Given this list of marker genes CLIP3, NFKBIA, RIPK1, ARHGEF37, USP4, ARHGEF18, ARHGEF3, MAG, FAS, ARHGEF33, APH1A, RNF31, ECT2, TIAM1, SMPD3, YWHAE, CYLD, RASGRF2, RELA, OTUD1, RPS27A, RBCK1, PSEN2, RHOA, MADD (MAP kinase activating death domain), BIRC2, SPATA2, TNFSF10, IKBKE, ARHGEF26, UBE2D2, HDAC2, ARHGEF38, CHUK, TNFRSF10B, ARHGEF10L, ARHGEF11, ARHGEF35, SPPL2B, TBK1, MCF2L, PSEN1, MAPKAPK2, ARHGEF17, USP21, IKBKG, ARHGEF6, SQSTM1, TNF, SOS1, TNFRSF1A, NFKB1, VAV1, STUB1, MAGED1, TNFRSF10D, OPG199, TAB1 (NCBI Gene Id 10454), UBE2L3, ARHGDIA (Rho GDP dissociation inhibitor alpha), UBC, TIAM2, SOS2, FASLG, CASP3, AATF, SPPL2A, ITGB3BP, KALRN, CASP2, UBB, OBSCN, NCSTN, TRAF1, PLEKHG5, NGFR, RIPK2, OTULIN, RAC1, ARHGEF19, MYD88, TRADD, FGD1, ARHGEF39, OMG, ARHGEF7, PREX1, MCF2, FGD4, IRAK1, CASP10, UBA52, IKBKB, ARHGEF4, PSENEN, CFLAR, AKAP13, UBE2D1, MAP3K7, ADAM17, ARHGEF1, CASP8, FADD, NSMAF, TAB3, ARHGEF15, BCL2L11, OPTN, MIB2, TRAF6, SMPD2, PLEKHG2, ITSN1, NET1, UL36, BIRC3, ARHGEF12, TAB2, RTN4R, NGF, GNA13 (NCBI Gene Id 147219), SHARPIN, VAV2, TNFRSF10A, TRIO, APH1B, ARHGEF9, XIAP, VAV3, RACK1, FGD2, BEX3, ULK1, ARHGEF40, OTUD7B, BAD, BAG4 (BAG cochaperone 4), TRAF2, ARHGEF16, TAX1BP1 (Tax1 binding protein 1), HDAC3, PRDM4, RTN4, ABR, USP2, MAPK8, HDAC1, LINGO1, ARHGEF5, TNFAIP3, PRKCI, SORCS3, ARHGEF10, UBE2D3, FGD3, ARHGEF2 (NCBI Gene Id 9181), NGEF, here is a description of the gene set: part of: Signal Transduction The death receptors (DR), all cell-surface receptors, that belong to the TNF receptor superfamily (TNFRSF). The term death receptor refers to those members of the TNFRSF that contain a "death domain" (DD) within their cytoplasmic tail which provides the capacity for protein–protein interactions with other DD-containing proteins suach as FADD. The main signals transmitted from TNF death receptors such as TNFR1, TRAIL-R, and CD95/FAS in response to their cognate ligand binding result in an apoptotic signaling pathway characterized by direct activation of intracellular cysteine proteases (caspases), without directly involving the mitochondrial death pathway. However, these death receptors have also been shown to initiate survival signals via the activation of transcription factors NFκappaB and AP1. This project describes an assembly of the death-inducing signaling complex (DISC) downstream of TNFR1, TRAIL-R, and CD95/FAS and shows protein composition and stoichiometry within the DISC. However, the DISC signaling complex may vary in its components stoichiometry. DR signaling may trigger formation of higher order receptor structures or signaling through rearrangement of receptor chains, which is not reflected here. The project also describes neuron-type-specific signaling by the p75NTR death receptor (also known as NGFR) that can regulate a number of different biological activities in response to ligand binding, including cell death and/or survival, axonal growth and synaptic plasticity. studied in species Homo sapiens Reactome Pathway: Death Receptor Signaling